Given this list of marker genes Foxa2, Dhcr7, Creb1, Fgf10, Lta4h, Nkx2-1, Foxp1, Trp73, Rbpj, Rbbp9, Ascl1, Foxj1, Foxa1, Grhl2, Kras, Ctnnb1, Foxp4, Tmem38b, Aimp2, Nfib, Fndc3b, Sav1, Yap1, Spdef, Ncor2, Agr2 (NCBI Gene Id 23795), Pthlh, Col6a1, Klf2, Thra (NCBI Gene Id 319227), Gata6, Ppp3r1, Igf1, Hoxa5, Thrb, Sox9, here is a description of the gene set: The process in which relatively unspecialized cells, e.g. embryonic or regenerative cells, acquire specialized structural and/or functional features of a mature cell found in the lung. Differentiation includes the processes involved in commitment of a cell to a specific fate. species: Mus musculus Mouse Gene Set: GOBP_LUNG_CELL_DIFFERENTIATION